Given this list of marker genes PLK3, TATDN2, NUFIP2, NYX, CAMKV, CBFB, LIPF, RALYL, C1orf174, SH3BP5, RBM38, CPSF7, HCCS, MYB, AVPR1A, RCAN1, PCMT1, CRYBA4, EPS15, ATP10A, DNMT3A, NDFIP1, FBXO45, ATP1A1, TXNRD3 (NCBI Gene Id 93415), FSTL5, SPN, GPR176, MIR22HG, NKG7, TAF1A, ARHGAP32, MRPL35, PDCD1, NQO1, KRAS, IPCEF1, KLRC1, WNT10B, NEB, CDK17, MZB1, MARVELD2, RRBP1, SPP1, TCF4, RAP2B, BCL10, ATG16L2, GBP7, GP9, BCOR, GRAMD1B, UBXN2A, BLNK, RETREG1, PKD2L1, HPGD, MMGT1, SOWAHB, TRPV6, ARX, SHISA2, PSMD11, SLC17A5, IZUMO1R, QRFPR, CCND2, SLC47A1, NRP1, EXPH5, BCAT1, CHML, MAP3K8, RASAL1, ORMDL1, ADAM10, MEGF8 (NCBI Gene Id 90198), TFAP2C, FYN, ZNF330, TACC2, SGK1, ANXA8, LRRC40, USP1, CST7, TAAR1, IDUA, RMI2, PLEKHA5, TRIM2, ADM, C19orf18, PCID2, PLA2G4D, SRSF7, VAMP5 (NCBI Gene Id 200553), USP34, SACM1L, ADAMTS6, PCDH17, PCGF5, TNFSF14, HSPA4L, MFSD6, EPCAM, TRAPPC11, PDZD2, ZCCHC13, RNF7, PLSCR1 (NCBI Gene Id 5359), ARHGEF3, TWSG1, IRF8, BMPR2, IL15RA, TLE3, PSMA5, BEND3, TMEM201, RBMX, PARD6G, HIVEP1, IFNG, PTPN22, GPR182, ORAI1, ST6GALNAC3, SNAI3, CHKA, DNMT3L, HIVEP3, MBP, FANK1, MFSD12, TSPAN2, MED7, SLC7A7, VAV3, FGF13, HBS1L, NCF1, AHCYL1, BMP4, HSF5, BUD31, SLC23A1, EHD1, HS6ST3, POFUT2, GFI1, PPT2, GUCY1A2, PNPT1, RBFA, AP1AR, WSB2, SMIM15, C5orf47 (NCBI Gene Id 133491), MRPS17, OMD, CCL2, PLCXD1, LNX2, PPWD1, MED14, PIWIL4, ITGA6, RILPL2, VSIR, MSH3, LARP7, COX5A, TTC19, PDS5A, SPP2, RER1, MCOLN2, MTERF3, COP1, NOL7, LCK, TMTC4 (transmembrane O-mannosyltransferase targeting cadherins 4), FRMD4A, ERAP1, MYO1E, GTDC1, EZH2, CCNA1, GRM3, CSMD1, SMCO4, PFKFB2, ZNRF1, PSMA1, ACTN1 (actinin alpha 1), ERF, EIF5B, here is a description of the gene set: CD4+ T cells that selectively produce interleukin (IL)-17, are critical for host defense and autoimmunity1-4. Crucial for T helper17 (Th17) cells in vivo5,6, IL-23 has been thought to be incapable of driving initial differentiation. Rather, IL-6 and transforming growth factor (TGF)-β1 have been argued to be the factors responsible for initiating specification7-10. Herein, we show that Th17 differentiation occurs in the absence of TGF-β signaling. Neither IL-6 nor IL-23 alone efficiently generated Th17 cells; however, these cytokines in combination with IL-1β effectively induced IL-17 production in naïve precursors, independently of TGF-β. Epigenetic modification of the Il17a/Il17f and Rorc promoters proceeded without TGF-β1, allowing the generation of cells that co-expressed Rorγt and T-bet. T-bet+Rorγt+ Th17 cells are generated in vivo during experimental allergic encephalomyelitis (EAE), and adoptively transferred Th17 cells generated with IL-23 in the absence of TGF-β1 were more pathogenic in this experimental disease. These data suggest a new model for Th17 differentiation. Consistent with genetic data linking the IL23R with autoimmunity, our findings re-emphasize the role of IL-23 and therefore have important implications for the development of new therapies. studied in species Homo sapiens Genes up-regulated in CD4 T cells: untreated versus IL6 and TGFB1. Human Gene Set: GSE23505_UNTREATED_VS_4DAY_IL6_IL1_TGFB_TREATED_CD4_TCELL_UP from publication Ghoreschi K, Laurence A, Yang XP, Tato CM, McGeachy MJ, Konkel JE, Ramos HL, Wei L, Davidson TS, Bouladoux N, Grainger JR, Chen Q, Kanno Y, Watford WT, Sun HW, Eberl G, Shevach EM, Belkaid Y, Cua DJ, Chen W, O'Shea JJ (PMID 20962846)